The following is a description of a gene set: Genes predicted to be targets of miRBase v22 microRNA hsa-miR-4716-5p in miRDB v6.0 with MirTarget v4 prediction scores > 80 (high confidence targets). species: Homo sapiens from publication Chen Y, Wang X (PMID 31504780) Human Gene Set: MIR4716_5P, and this is the list of marker genes: COBLL1, IGSF5, SETBP1, FUT8, TMLHE, PRRC2C, BTG1, SP3, JAKMIP2, TMEM106A, ZDHHC17, ELK3, GRIA2, CCDC43, HMGA2, ARHGEF38, CEP135, RABIF, GPRIN3, DIP2C, HIPK3, BORCS7, TRAPPC3, SHPRH, UBE2K (ubiquitin conjugating enzyme E2 K), MFHAS1, NAMPT, ARHGEF33, TCTN1, ATOH8, AASDHPPT, ZNF644, DHODH, PCDH7, EDNRB, STAC, CERS2, TM9SF3, RANBP9, GRM3 (NCBI Gene Id 2913), SLC39A9, IPPK, MAGEA10, ATP2B2, ACSS3, ADAM12, KCNJ11, CRISPLD1, SCAF8, ISY1-RAB43, GRID2, MFSD6, UGT8, MTHFD1L, ERLIN2, TSPYL5, MTMR1, ADAM22, SHANK2, RNF220, SLC24A1, SRSF2, TTC13, ZEB2, PDCD6, SH3RF3, ZFHX4, CGRRF1, SMG1, ERC2, ZNF480, SUPT6H, RBM41, MSTN, SSX2IP, DZIP3, RAB43, VLDLR, HMGN3, HEXA, EGLN1, MAPDA (N6-Methyl-AMP deaminase), RBM46, TLNRD1, PPDPFL, NFIA, LILRA4, SLC9A7, PIKFYVE, CPSF6, ZNF571, LRRC4B, ZNF197, AP1S2, NKAIN3, TAFA2, BMP2K, PGS1, FKBP5, ZNF568, TLE4, BDH2, DAG1, RABGAP1, LZIC, POLR3C, ZFX, MBNL3, DIXDC1, RASA3, CCR10, TMEM8B, BSDC1, SGK1, GCFC2, DACH2, ZNF772, PICALM, MAP3K7CL, SYT4, OSBPL3, KCNS3